Given this list of marker genes Ap1ar, Itch, Dlc1, Epb41l5, Mia3, Fzd7, Clasp2, Coro1c, Ppm1f, Mbp, Spaca7, Ripor2, Actn4, Ephb2, Bmp6, Dscaml1, Cd69, Phldb2, Cdkn2a, Lax1, Postn, Pten, Pdcd1lg2, Epha5, Tnr, Dusp1, Src, Spry4, Rgcc, Lamb1 (NCBI Gene Id 97822), Fbln1, Thbs1, Dlg5, Ifnb1, Tnfrsf14, Ptpn1, Rnd1, Jam2, Abca12, Rag2, Mmp12, Hspb1, Il20rb, Ccl21b, Cxcl12, Ptpn2, Tbcd, Vsig4, Cd24a, Jak3, Acvrl1, Pdcd1, Sdc4, Socs5, Ido1, Loxl3, Btn2a2, Il10, Prkar1a, Tspan32, Tigit, Cd300a, H2-T23, Laptm5, Tgfb1, Clec4g, Tmx1, B4galnt2, Ccl21a, Foxp3, Havcr2 (NCBI Gene Id 268402), Plxnd1, Bcar1, Mad2l2, Zc3h12d, Tnfaip3, Gimap3, Bmp4, Myo1f, Cd9, Ccl21f, Tbx21, Ccm2l, Muc21, Crtam, C1qtnf1, Tnfaip8l2, Gtpbp4 (NCBI Gene Id 85330), Adamts18, Fgl1, Nrarp, Bmp2, Ppara, Jak2, Angpt1, Serpine1, Enpp2, Mmp2, Xcl1, Mad1l1, Hspg2, Vegfa, Pawr, Peli1, Il1rn (interleukin 1 receptor antagonist), Shh, Mapk7, Tarm1, Itgb1bp1, Lrrc32, Mdk, Btla, Tacstd2, Rcc2, Slfn1, Glmn (NCBI Gene Id 170823), Plxnb3, Scgb1a1, Spi1, Notch1, Coro2b, Cbfb, Zfp608, Ihh, Adtrp, Ceacam1, Twsg1, Ccl28, Lpxn, Jag1, Abl1, Ccl21d, Hoxa7, Ildr2, Efna5, Apod, Nat8f3, Lilrb4a, Rasa1, Slc4a2, Ass1, Prkcd, Muc1, Spn, Cd80, Zc3h8, Cebpb, Kng1, Zfp35, Prdx2, Nf2, H2-M3, Dusp22, Cd37, Notch4, Gpnmb, Klf4, Pf4, Dact2, Hrg, Ptpn11, Cfl1, Gstp1, Col1a1, Fzd4, Tsc2, Trpv4, Nat8, Sema3e, Tnc, Tnfrsf21, Myadm, Il2ra, Cd86, Zc3h12a, Tnfsf18, Zbtb7b, Dusp3, Plxnb2, Map2k1, Dtx1, Hmgb1, Kng2, Irf1, Wnk1, Swap70, Pde5a, Rhoa, Ccl25 (NCBI Gene Id 320542), Nat8f1, Acp5, Cldn7, Runx1, Men1, Cd44 (NCBI Gene Id 99339), Sftpd, Sema6a, Gnrh1, Epha4, Sh2b3, Podxl, Arg1, Smad7, Pde3b, Plg, Lgals3, Nfkbid, Spint2, Dscam, H2-Aa, Pla2g2d, Pla2g2a, Adora2a, Map2k5, Abl2, Prkg1, Il4ra, Ptpn6, Erbb2, Ythdf2, Ptk2, Sema5a, Cblb, Il4i1, Cdh1, Lgals9, Lgals1, Vsir, Kank1, Ndfip1, Spock1, Plxnc1, Arg2, Alox12, Pag1, Ptpn22, Ascl2, Il4, Gcnt2, Ctsg, Mettl3, Tnfsf4, Jam3, Dab1, Cbll1, Srcin1 (NCBI Gene Id 56013), Zfp703, Marchf7, Cd274, Lrp1, Sema4d, Casp3, Ptprz1, Adam10, Bcl6, Defb21 (NCBI Gene Id 403172), Adam8, Meltf, Rdx, Ubash3b, Acer2, Prnp, Fam107a, Myoc, Socs1, Ager, Pla2g5, Fgl2, Vtcn1, Specc1l, Lag3, Atp5f1b, Akna, Mmp14, Dlg1, Adam15, Anxa1, Epcam, Apoa1, Gimap5, Hfe, Rc3h2, Pla2g2f, Ajap1, Nat8f5, Ctla4, Cd276, Nexmif, Snai2, Muc4, Tmem131l, Adipoq, Nf1, Socs6, Ufl1, Nat8f2, Dmtn, Akt1, Serpine2, Pik3r1, Rc3h1, Il2, Plet1, Hlx, Cyp1b1, Lilrb4b, Wnt1, Arhgap6, Ptprc, Cd74, Foxj1, Scrib, Runx3, Plxnb1, Ccl21e, Dapl1, Cask, Gli3, Cdh13, Erbb3, Cdsn, Angpt2, here is a description of the gene set: Mouse Gene Set: GOBP_NEGATIVE_REGULATION_OF_CELL_ADHESION Any process that stops, prevents, or reduces the frequency, rate or extent of cell adhesion. species: Mus musculus